Given this list of marker genes DLL3, NOTCH1, DLL1, PBX3, LFNG, here is a description of the gene set: The regionalization process in which embryonic segments are divided into compartments that will result in differences in cell differentiation. species: Homo sapiens Human Gene Set: GOBP_COMPARTMENT_PATTERN_SPECIFICATION